The following is a description of a gene set: Mouse Gene Set: GOBP_LIPID_CATABOLIC_PROCESS The chemical reactions and pathways resulting in the breakdown of lipids, compounds soluble in an organic solvent but not, or sparingly, in an aqueous solvent. species: Mus musculus, and this is the list of marker genes: Cyp26c1, Acer1, Enpp6, Cidec, Smpdl3a, Abcd3, Pck1, Pla2g12b, Lpin1, Pnpla8, Iah1, Cyp26a1, Pnpla7, Lipe, Cpt2, Gimap5, Pex5, Cyp46a1, Lipi, Hint2, Pla2g7, Idh1, Ilvbl (ilvB (bacterial acetolactate synthase)-like), Rarres2, Dbi, Plin1, Abhd6, Apoa4, Twist1, Srd5a3, Plbd2, Nudt8, Hsd17b6, Abcd4, Pafah1b1, Ugt1a7c, Pex2, Decr2, Apoe, Gba1, Apoc1, Lipn, Plaat1 (phospholipase A and acyltransferase 1), Ces1b, Plcb1, Ehhadh, Apoc2, Cyp1a2, Plin5 (perilipin 5), Akt1, Etfdh, Bscl2, Dagla, Abcd1, Aoah, Dgkd, Galc, Slc27a4, Echdc1, Hsd3b7, Ech1, Plpp6, Pla2g2a, Aldh1l2, Lep, Pnpla1, Lipf, Lipg, Mtor, Plaat3, Sorl1, Clpsl2, Fitm2, Faah, Pla2g6, Lrcol1, Pafah1b3, Lpin2, Lpl, Ywhah, Acad11, Hao1, Eci3, Cyp24a1, Aig1 (NCBI Gene Id 66253), Hsd17b14, Cel (NCBI Gene Id 78484), Vps54, Asah2, Slc25a17 (NCBI Gene Id 58177, solute carrier family 25 (mitochondrial carrier, peroxisomal membrane protein), member 17), Scp2, Crot, Hexa, Naglu, Sp1, Cidea, Acaa2, Pex13, Acaa1b, Neu1, Eci2, Angptl3 (NCBI Gene Id 30924), Nceh1, Acer3, Plcz1 (phospholipase C, zeta 1), Neu4, Plb1, Pafah1b2, Lonp2, Plce1, Lypla2, Enpp7, Pnpla2, Smpd1, Pla2g4b, Ces1a, Echdc2 (NCBI Gene Id 69899), Acsbg2, Hsd17b4, Etfbkmt, Dpep2, Psap, Abhd3, Apoc2l, Gpld1, Acads, Thra, Pla2g15, Cyp39a1, Acaa1a, Aadac, Srd5a1, Cyp4f13, Lpin3, Mlycd, Hcar2, Abhd12b, Gdpd1, Acsl5, Naaa, Prkaa1, Nudt7, Abhd16a, Sesn2, Cyp27a1, Akt2, Pcca, Plbd1, Lipa, Pex7 (NCBI Gene Id 18634), Pla2g4e, Etnppl, Ppt1, Mgll, Plcd3, Acox1, Inpp5f, Cyp2w1, Abhd16b, Hsd17b10, Endou, Acadm, Smpd2, Crtc3, Pla2g4f, Glb1, Daglb, Aspg, Gla, Cyp26b1, Adora1, Acox2, Irs1, Ptprv, Abhd4, Fabp1, Abhd15, Hexb, Apob, Ces1d, Pla2g5, Pld6, Gpihbp1, Tnf, Plcxd2, Eci1, Srd5a2, Pik3cg, Ins1, Cyp7a1, Auh, Cp, Bco2, Obp2a, Pla2g4d, Fmc1, Pla2g2f, Ldlr, Pla2g1b, Liph, Pla2g2e, Cpt1b, Abcb11, Ces1c, Pnpla6, Ces1e, Adra2a, Hsd11b1, Plch2, Il1b, Naga, Acat1, Smpd4, Plcxd3, Pnlip, Acad12, Bco1, Ces1h, Akr1d1, Tysnd1, Strap, Echs1, Apoh, Pck2, Cnr1, Acot2, Akr1c18, Gpcpd1, Etfb, Hadha, Acad10, Sco1, Acacb, Hadh, Acap1, Plcg2, Pla2g2c, Hsd17b11, Prkce, Abhd5, Acadl, Phyh, Pafah2, Gcdh, Hacl1, Abhd12, Apoc3, Hadhb, Gm2a, Acer2 (alkaline ceramidase 2), Oxct1, Pde3b, Pla2g10, Zpbp2, Ivd, Acot7, Rab7, Prdx6, Plcg1, Cyp27b1, Plch1, Pnpla3, Abhd2, Crat, Clps, Sirt2, Cyp19a1, Dpep1, Oxct2a, Sult2a8, Gdpd3, Cps1, Acoxl, Sult1e1 (sulfotransferase family 1E, member 1), Pld2, Clstn3, Pla2g4a, Klf9, Adipoq, Plcb2, Sirt6, Apoa5, Bglap2, Cyp4f18, Fgf23, Decr1, Oxct2b, Sctr, Plcd1, Cyp1b1 (cytochrome P450, family 1, subfamily b, polypeptide 1), Adtrp, Gba2, Lipm, Ppard, Cyp4f14, Ces1f, Mfsd2a, Pla2g4c, Napepld, Hcar1, Tbl1xr1, Asah1, Abcd2, Prkcd, Acox3, Abhd1, Smpd5, Ins2, Spart, Alk, Prdx6b, Pnliprp2, Plcb3, Oc90, Lipk, Pla1a, Cpt1a, Pnliprp1, Pla2g12a, Sgpl1, Irs2, Cyp4f40, Pla2g2d, Nudt19, Neu2, Slc27a2, Ddhd2, Fgf21, Scarb1, Neu3, Enpp2, Acot8, Lipc, Smpd3, Plcd4, Flvcr2, Lrp1, Ces1g, Acadvl, Mtln, Etfa (electron transferring flavoprotein, alpha polypeptide), Bdh2, Hpgd, Sct, Pnpla5, Cyp4f15, Gimap3, Pld1 (NCBI Gene Id 99508), Smpdl3b, Apoa2, Mgst2, Amacr, Spp1, Lct